The following is a description of a gene set: Any process that activates or increases the frequency, rate, or extent of toll-like receptor 4 signaling pathway. studied in species Homo sapiens Human Gene Set: GOBP_POSITIVE_REGULATION_OF_TOLL_LIKE_RECEPTOR_4_SIGNALING_PATHWAY, and this is the list of marker genes: PTPN22, TICAM2, WDFY1, CD14, NINJ1, NR1H3, IFI35, ZNRF1, F2RL1, PELI1, TIRAP, HMGB1, LTF, LBP